The following is a description of a gene set: Human Gene Set: GSE40441_NRP1_POS_INDUCED_TREG_VS_NRP1_NEG_NATURAL_TREG_UP To compare subpopulations of Treg cells in wild type mice based upon Nrp1 Expression, differentiating nTreg and iTreg Genes up-regulated in T reg: NRP1+ versus NRP1-. studied in species Homo sapiens from publication Weiss JM, Bilate AM, Gobert M, Ding Y, Curotto de Lafaille MA, Parkhurst CN, Xiong H, Dolpady J, Frey AB, Ruocco MG, Yang Y, Floess S, Huehn J, Oh S, Li MO, Niec RE, Rudensky AY, Dustin ML, Littman DR, Lafaille JJ (PMID 22966001), and this is the list of marker genes: AP3M2, PPFIBP1, SEC24D, PTPN13, NFKBIE, LHX6, DRD2, FCMR, ATP6V0D2, RNH1, IZUMO1R, RNF216, CPSF4L, HLA-DOA, DENND2B, DAGLB, GPR15, DUSP16, SAPCD1, ILDR1, RNLS, P2RX7, OSBP2, CAMK2B, ZNF423, CD79B, XPO4 (exportin 4), SEMA4F, CDX2, SNX31, SOAT1, TIAM1, THADA, IL4, SYNPO2, KCTD17, ASPHD1, PTPN22, KATNAL1, LBR, FGD6, SDHAF1 (succinate dehydrogenase complex assembly factor 1), CCDC22, CYTH4, BATF, DENND4C, ASS1, LCLAT1, TM7SF3, FGD4, CCN4, RIPK4, CDC42EP3, MARCHF3, DENND2C, RNF128, MYOZ3, GGACT, ITPK1, TMEM243, STARD10, IL6R, ECI1, TRAF5, CCNG1, RPL12, NCF4, LYPLA2, HDAC9, DTX4, IFT43, ARHGEF16, TNP2, TREM2, ITGAE, RGS6, TRAF3IP2, UBASH3A, F2RL1 (NCBI Gene Id 7901), GDF11, ALDOC, PLAUR, DEK, KLF5, SYNGR4, IGF1R (NCBI Gene Id 51049), PCTP (NCBI Gene Id 94001), ITGA7, LIPH, STAC2, IL16, RXRA, PSCA, CCDC127, CXCR5, ZC3H12C, SERINC2, BAALC, SH3BGRL, TMEM30B, SUPT7L, TSPYL2, ZCCHC3, RFLNB, FAM111A, DOC2A, PDGFB, C16orf54, FECH, UNC119, ALDOA, FHIP1A, CSF3R, WWC1, MAN1C1, ZBTB42, PDE2A, TRIM17, BZW2, TJP2, CAPG, RGS3, GEMIN8, IL1R2, TMEM143, ARRDC4, KCNIP4, FAM222A, SLAMF6, RAB43, SYNGR2, INPP4B, CREB1, NUCB2, NFKBIL1, GABRA3, PROX2, AMPD3, PRG4, ST8SIA4, CCDC30, RAD51B, SQOR, IER5L, GALM, GPM6B, ZBTB8A, RNF144A, ARHGEF3, IDE, MYO3B, SNX9, AHCYL1, MBOAT1, SLC7A10, PARP16, JAK1, CACNB1, ARHGAP39, CCDC110, BANK1 (B cell scaffold protein with ankyrin repeats 1), ONECUT3, TAF9B, MATN4, E2F2, PTGER2, ENDOG, RNF43, GRP, SNTB1, NFASC, NLN, SLC12A2, CYP4V2, P2RY10, TMEM209, SLC22A5, TRPC7, COQ8A, ANKMY2, GJB4, CSF1, NCAM1, SHE, RNF19B, ANKH, ABHD4, NT5E, SYT11, S100A10 (S100 calcium binding protein A10), TESC, GBP4, GPR4, CERS4, PYCR1, GSX1, SH3GL2, PADI1, GPX6, ZNF112